Given this list of marker genes GOLM1, TMBIM1, RGS14, RAD50, KCTD10, CADM1, FLNB, SLC44A1, CPT1A (carnitine palmitoyltransferase 1A), HHEX, RMND5A, PHTF2, APLP2, MRPL42, RPL6, RPS18, CAPN7, GPX4, ZNF362, ADAM8, STRBP, GRSF1, PPP1R21, TRIM28, PCK2, MAGED1, PCYT1A, RETREG1, HADH, TNFRSF21 (NCBI Gene Id 51323), CD14, RNF166, PTPRA, NFYA, AP1AR, RPL36, RTN4, LIN9, CARD19, SMS, LPL, CTPS2, BRI3, PIGQ, MBNL1, RPS6KA2 (NCBI Gene Id 6196), RALBP1, NBEAL2, PTCD3, NINJ1, SLC27A1, PON2, TMEM131, SAP30, SIGMAR1, NEDD9, CORO1A, CD68, TSC22D1, ANKH, DNASE1L1, GCSH, RCC2, GIPC2, MID1IP1, PDCL3, ARHGAP39, MLH1, ARRB1, PDHA2, UBL3, FUT8, CRYBG1, NPC1, CMAS, DENND4C, ZNF688, HCFC1, ACLY, PRKAG1, SLC35E4, H6PD, PRKCB, ACOT13, SQSTM1, DEGS1, GSTO1, NFIC, SMAD6, VAPB, DNAJB4, PRKAR2A, LRWD1, ALDH2, FBXO45, EIF3L, RELL1, ALDH9A1, ASPM, NRP1, NAP1L1, PRKCD, CEACAM21, TTC3, SPTSSA, PJA1, INCENP, S100A8, HAL, MLEC, CSNK2B, GCLC, RRAGC, GABARAPL2, HNRNPH1, TRIM47 (tripartite motif containing 47), ANTKMT, FADS1, IKBIP, MYADM, HSPA1B, UROD, ACTN1, MFHAS1, QDPR, GLUD1, SLC6A8, IGF1, IDH3G, NDFIP1, ADSS2, LRBA, WDR6, CAPN2, ARMC10, KIF22, AQP8, MYCBP2, MRPL17, SLC6A12, PDE6D, VPS37B, SLU7, USE1, STX2, ST3GAL5, SPDL1, IVNS1ABP, ZSCAN21, YWHAH, FAM20C (FAM20C golgi associated secretory pathway kinase), NCOR2, SUCLG2, TRPV2, TNRC6A, FBXO21, CAB39, CKB, PMP22, LAMTOR2, PCMT1, HMGA2, MSH2 (mutS homolog 2), AHNAK, DICER1, CXCL3, SLMAP, CASP9 (caspase 9), MBP, DAG1, TNIP1, ZFP36L2, CUEDC1, TKT, KIF23, TEN1, PTPN22, CSNK1E, GLCE, FOS, USP48, CLN6, DSTN, KANSL2, NDUFA8, PARP1, BCL2L10, MEPCE, RASA3, MDM2 (NCBI Gene Id 84825), MAPK14, TALDO1, CRIP1, DRG1, ADSS1, FRYL, AP5S1, SERPINB6, GNA12, ISYNA1, here is a description of the gene set: from publication Kohn LA, Hao QL, Sasidharan R, Parekh C, Ge S, Zhu Y, Mikkola HK, Crooks GM (PMID 22941246) Human Gene Set: GSE35685_CD34POS_CD10NEG_CD62LPOS_VS_CD34POS_CD10POS_BONE_MARROW_UP Genes up-regulated in the bone marrow CD34+ cells: MME- SELL+ versus MME+. studied in species Homo sapiens Studies of adult human hematopoiesis have until now relied on the expression of CD10 to define lymphoid commitment. We report a novel lymphoid-primed population in human bone marrow that is generated from hematopoietic stem cells (HSC) prior to the onset of CD10 expression and B cell commitment, and is identified by high levels of the homing molecule L-selectin (CD62L). CD10-CD62Lhi progenitors have full lymphoid (B/T/NK) potential, and show reduced myeloid and absent erythroid potential. Genome-wide gene expression analysis demonstrates that the CD10-CD62Lhi population represents an intermediate stage of differentiation between CD34+CD38- HSC and CD34+lin-CD10+ progenitors marked by down-regulation of TAL1 and MPL, upregulation of E2A, CD3E and IL2RG expression, and absent B cell commitment or RAG1/2 expression. Immature CD34+CD1a- thymocytes are also CD62Lhi and L-selectin ligands are expressed at the cortico-medullary junction, suggesting a possible role for L-selectin in human thymic homing. These studies identify the earliest stage of lymphoid priming in human bone marrow.